Given this list of marker genes CYP19A1, TNFRSF10A-DT, ZNF230, ENSG00000291179, PPIH, LURAP1, GP6, LINC01281, ANKRD49, BCDIN3D, PFKFB1, ATOSB, WSB1 (WD repeat and SOCS box containing 1), STUB1-DT, SFRP2, PDE12, LAMA4 (NCBI Gene Id 3910), RIT2, SOCS6, ANKRD65, PER3, GTSE1, FRMPD3, RECQL5, TMEM132A, ZNF384, PLEKHN1, ANKRD1, CXCR5, POU5F1P3, FOXN1, ZFHX2, TACO1, SLC22A6, MINDY1, TMC2, CREB3L1, CASC11, LCN8, TAF7L, AQP6, CORO6, DZIP1L, TMEM239 (NCBI Gene Id 100291571), CYP4F29P, OXSM, ANAPC16, CDX2, GANAB, CYB5A, RGS7BP, SSTR5, OR1F1, MIR34BHG, NYNRIN, STARD9, CEP70, EVC, TGM7, GLRB, ITGA2B, QPRT, TCAP, CAV2, EPS8L2, CD276 (CD276 molecule), MYL4, TAC3, H1-6, LGALS8-AS1, KCNK16, ZNF528, KCNJ5-AS1, IRX2, CRABP2 (NCBI Gene Id 1382), TMEM213, ADAMTS15, FUT8-AS1, KDM2B, EMC4, DDX52, TMEM102, CDC42EP2, ZNF641, FRMD3, CYP20A1, FNTA, BCL7A, TINAGL1, REX1BD, LRSAM1 (NCBI Gene Id 90678), DMAP1, IGHV5-78, ECM1, ZNF683 (zinc finger protein 683), FHL2, LEO1, GSN (NCBI Gene Id 2934), BFAR (bifunctional apoptosis regulator), FAAP24, MYLK (myosin light chain kinase), TMEM232, CYP4F3, LETR1, ITGA3, HOXD10, APOC2 (NCBI Gene Id 344), ZNF502, CA4, GGACT, SHE, FZD5, XYLB, MTA3, SORBS3, SZT2, TPGS1, EPHB3, TULP1, OR2C3, PLGLB2, ABCD1, RBM39, ZNF562, CLEC2L, MAPK8, SERPINA5, HNF1A, CYP2A7P1 (cytochrome P450 family 2 subfamily A member 7 pseudogene 1), UBE2CP4, ZNF80, DHX16, CLVS2, CTSE, LIFR-AS1, HINT2, APCS, NOS1, NKAP, WFDC8, PVALB, SALL1, PGAM2, BHLHE22, LINC00485, GJA3, OR1A2 (olfactory receptor family 1 subfamily A member 2), CASQ1, PPFIA4, RBP7, AHSP, DECR2, HLCS, MCM3, ZNF705G, CACNA2D1, RAMAC, MAP2K4, IGLV3-19, UPK2, RGPD5, C1QTNF7, MAIP1, CHRNB3, KANSL1L, COL3A1, AMBP, LRRK2, PPP1R14A, RAMP2-AS1, ZNF391, CFAP46, BPIFB6, ZNF621, FER1L6-AS1, HHLA1, LTC4S, CTTN, CLEC4F, HOXB1, CFAP410, ENTPD1, OR2C1 (olfactory receptor family 2 subfamily C member 1), FGF11, ZNF628, SMIM10L2B-AS1, RNF2, VWA5B2, LINC01123, TLCD3B, HIGD1B (NCBI Gene Id 51751), MROH7, LINC01364, EIF2B5, MSTO1, MYO1A, TOR1AIP2, here is a description of the gene set: studied in species Homo sapiens Genes down-regulated in thymus perimedullary cortical region versus the whole medulla. Human Gene Set: GSE18281_PERIMEDULLARY_CORTICAL_REGION_VS_WHOLE_MEDULLA_THYMUS_DN Interaction of hematopoietic progenitors with the thymic stromal microenvironment induces them to proliferate, adopt the T cell fate, and asymmetrically diverge into multiple T lineages. Progenitors at various developmental stages are stratified among different regions of the thymus, implying that the corresponding microenvironments differ from one another, and provide unique sets of signals to progenitors migrating between them. The nature of these differences remains undefined. Here we use novel physical and computational approaches to characterize these stromal subregions, distinguishing gene expression in microdissected tissues from that of their lymphoid constituents. Using this approach, we comprehensively map gene expression in functionally distinct stromal microenvironments, and identify clusters of genes that define each region. Quite unexpectedly, we find that the central cortex lacks distinctive features of its own, and instead appears to function by sequestering unique microenvironments found at the cortical extremities, and modulating the relative proximity of progenitors moving between them. from publication Griffith AV, Fallahi M, Nakase H, Gosink M, Young B, Petrie HT (PMID 20064453)